Given this list of marker genes Grpel1, Psme2, Prdx1, Calr, Tubb4b, Set, Igfbp4, Plac8, Ncl, Atp5mc1, Scamp3, Ldha, Eif4a1, Timm8a1, Nop56, Tuba1a, Mettl1, Sars1, Ppp1r14b, Mrpl42, Socs3, Eif5a, Ndufaf8, Nme1, B4galnt1, Psmb8, Arpc1b, Hopx, Ndufb7, Phgdh, Ly6a, Ppa1, Tmem14c, Aprt, Pa2g4, Srsf3, Nsun2, here is a description of the gene set: Cytokines mediate cell-cell communication in the immune system and represent important therapeutic targets. A myriad of studies have highlighted their central role in immune function, yet we lack a global view of the cellular responses of each immune cell type to each cytokine. To address this gap, the authors created the Immune Dictionary, a compendium of single-cell transcriptomic profiles of more than 17 immune cell types in response to each of 86 cytokines (>1,400 cytokine-cell type combinations) in mouse lymph nodes in vivo. A cytokine-centric view of the dictionary revealed that most cytokines induce highly cell-type-specific responses. For example, the inflammatory cytokine interleukin-1β induces distinct gene programmes in almost every cell type. A cell-type-centric view of the dictionary identified more than 66 cytokine-driven cellular polarization states across immune cell types, including previously uncharacterized states such as an interleukin-18-induced polyfunctional natural killer cell state. from publication Cui A, Huang T, Li S, Ma A, Pérez JL, Sander C, Keskin DB, Wu CJ, Fraenkel E, Hacohen N (PMID 38057668) species: Mus musculus Genes positively differentially expressed in cell type: γδ T cell upon treatment with cytokine: IL-21 in mouse lymph nodes in vivo. Mouse Gene Set: CUI_T_CELL_GD_IL21_RESPONSE_UP